The following is a description of a gene set: Human Gene Set: KEGG_MEDICUS_PATHOGEN_HCMV_UL33_TO_GNB_G_RHO_SIGNALING_PATHWAY studied in species Homo sapiens HCMV UL33 to GNB/G-Rho signaling pathway. Pathway ID: N00409. Pathway type: Pathogen. Pathway class: nt06167 Human cytomegalovirus (HCMV). Pathway Definition from KEGG: UL33 -> GNB/G -> RHOA -> MAP2K6 -> p38 -> CREB, and this is the list of marker genes: GNB1, GNG7, GNB5 (NCBI Gene Id 82962), CREB3L4, GNB4, MAPK14, MAPK11, ATF6B, CREB5, GNGT1, ATF4, GNG13, CREB3L1, GNG8, GNG12, CREB3L3, ATF2, GNG4, RHOA, CREB1, GNGT2, GNG2 (G protein subunit gamma 2), GNG5, GNB2, CREB3L2, CREB3 (NCBI Gene Id 10488), MAP2K6, MAPK13, GNB3, GNG3, GNG10, GNG11 (NCBI Gene Id 2791), MAPK12